Given this list of marker genes Defa3, H2-D1, Lyn, Pdia4, Serpina1b, Defa31, Mpeg1, H2-DMb1, H2-Eb1, H2-T10, Gatm, Klk1, Ctrb1, H2-Q1, Uba7, Ctsc, Psmb10, Ero1a, Cxcl5, Klk1b4, Cd14, Upp1, Plac8, Ugt2b38, Bst2, Stat1, Prss3b, Cela1, Psme2b, H2-Q2, Mup5, Gbp2, Ccl5, H2-T13, Slc16a1, Ifi44, H2-K1, Slc40a1, Ly75, H2-DMa (NCBI Gene Id 14998), D17H6S56E-5, H2-T23, Flot1 (NCBI Gene Id 14251), Aif1, Serpini2, Cd74, Socs1, Ctss, H2-Aa, Sp110, Klk1b9, Gast, Arg2, Prss3, H2-DMb2, Nfkbiz, Iigp1c, Psmb8, Tgtp1, H2-Q7, Cmpk2, Psmb9, Casp7, Gk, Ccl8, Casp1 (caspase 1), Krt16, B2m, H2-K2, Dmbt1, Tap2, H2-Ab1, Ambp, Tff3, Gbp4, H2-Q4, Tlr2 (toll-like receptor 2), Defa26, Klk1b3, Muc17, Tfrc, Dusp28, here is a description of the gene set: species: Mus musculus from publication Wunder C, Churin Y, Winau F, Warnecke D, Vieth M, Lindner B, Zähringer U, Mollenkopf HJ, Heinz E, Meyer TF (PMID 16951684) Genes up-regulated in gastric mucosal tissue of mice on 2% cholesterol diet and infected with H. pylori vs those infected with H. pylori while on 0% cholesterol diet. Helicobacter pylori infection causes gastric pathology such as ulcer and carcinoma. Because H. pylori is auxotrophic for cholesterol, we have explored the assimilation of cholesterol by H. pylori in infection. Here we show that H. pylori follows a cholesterol gradient and extracts the lipid from plasma membranes of epithelial cells for subsequent glucosylation. Excessive cholesterol promotes phagocytosis of H. pylori by antigen-presenting cells, such as macrophages and dendritic cells, and enhances antigen-specific T cell responses. A cholesterol-rich diet during bacterial challenge leads to T cell-dependent reduction of the H. pylori burden in the stomach. Intrinsic alpha-glucosylation of cholesterol abrogates phagocytosis of H. pylori and subsequent T cell activation. We identify the gene hp0421 as encoding the enzyme cholesterol-alpha-glucosyltransferase responsible for cholesterol glucosylation. Generation of knockout mutants lacking hp0421 corroborates the importance of cholesteryl glucosides for escaping phagocytosis, T cell activation and bacterial clearance in vivo. Thus, we propose a mechanism regulating the host-pathogen interaction whereby glucosylation of a lipid tips the scales towards immune evasion or response. Mouse Gene Set: WUNDER_INFLAMMATORY_RESPONSE_AND_CHOLESTEROL_UP